Given this list of marker genes ST8SIA1, AKAP13, CLDN12, GPCPD1, TIGD2, FRMD6, STAT2, BCL2A1, JCAD, TRIM25, ASAP1, SFXN3, SCD, FRMD4B, GALNT7, DENND11, CALCOCO1, PIK3CG, KDM1A, TTC3, MLLT3, IRGM, BCKDHA, EPSTI1, RPS6KA3, PBK (PDZ binding kinase), ZNF496, SYTL2, SMS (NCBI Gene Id 6735), NFE2L2, ZNF703, ENTPD1 (NCBI Gene Id 953), HIVEP3, CD82, UNG, MGAT4A, AAK1, CAPN3, TMEM243, AKT3, RALGPS2 (Ral GEF with PH domain and SH3 binding motif 2), CNOT6, PPP1R16B, NSG2, PRNP, NRN1, C19orf12, EXTL2, CIR1, IKZF3, ITK, TIAM1, DUSP2, RAD52, FOSL2, PRXL2A, MTNAP1, SESTD1, BATF3, SLC30A1, ICAM1, TENT5C, PCK2, TNFSF4, IRF9, JMJD1C, CYP2S1, BMP2K, FOXP1, VARS1, SPECC1, TOR3A, USP32, EPAS1, FAM107B, ANXA3, NFIL3, RGS10, LIF, MAEA (macrophage erythroblast attacher, E3 ubiquitin ligase), NIBAN1, NATD1, TES, YPEL2, ZNF367, RSPH3, CHD7 (NCBI Gene Id 780907), TMEM40, CUL7, SERPINF1, PDE3B, C3orf80, MED30, ABHD17B, OSER1, CCNG2, ERI2, PRR5L, SAMSN1, WDR12, GAB2, DUSP4, DDX50, MXI1, MCM3, CD9, NGLY1, AHR, ZBTB11-AS1 (ZBTB11 antisense RNA 1), FAM117B, C1QTNF12, NSD3, RMND5A, PLEK, TNFAIP8, MELK, PLCG1, ZNF250, RFX5, OGA, RRAGD, IDH2, TLE1, RCSD1, ST13, PARP14, SFMBT2, DEGS1, MTURN, PTGER4, VEZF1, GJA1, RELB, WDR6 (WD repeat domain 6), MAPKAPK2, RESF1, PSPC1, DAPL1, TNFSF13B, VCL, MTMR3, APEX1 (apurinic/apyrimidinic endodeoxyribonuclease 1), MAPK6, INPP5F, SLC25A53, ARHGAP15, PPP2CB, CASP7 (caspase 7), HMGB3, DAP, DGKD, TUT4, HECA, ABTB1, GOLIM4, KLRD1, SSH2 (NCBI Gene Id 85464), ATXN1, GBP6, NAMPT, RASGRP1, IL17RA, MGAT5, TBX21, PPP1R10, UBE2E3, ARL5A, PIP4K2A, TBL1XR1, CCDC122, LITAF, TENT2, TLCD2, SLC15A3, TAF5, DOCK10, NDRG1, RNF149, TGFB1, ADAMTS6 (NCBI Gene Id 345667), HDAC5, UNC93B1, AGL, CD96, MICAL1, SRPK1, CPD, SLC41A1, ACBD6, NOPCHAP1, CDT1, MXD1, FDPS, BIVM, FADS2, ALDOC, MXD4, ARAP2, TAP1, KTN1, here is a description of the gene set: Human Gene Set: GSE22601_IMMATURE_CD4_SINGLE_POSITIVE_VS_DOUBLE_POSITIVE_THYMOCYTE_DN Genes down-regulated in immature CD4 single positive cells versus double positive thymocytes. species: Homo sapiens T cells develop from progenitors that migrate from the bone marrow into the thymus. Thymocytes are subdivided roughly as being double negative (DN), double positive (DP), or single positive (SP), based on the expression of the CD4 and CD8 coreceptors. The DN stage is heterogeneous and can be subdivided into four distinct subsets in mice based on the expression of CD44 and CD25. In human, three distinct DN stages can be recognized: a CD34+CD38−CD1a− stage that represents the most immature thymic subset and the consecutive CD34+CD38+CD1a− and CD34+CD38+CD1a+ stages. Human DN thymocytes mature via an immature single positive (ISP CD4+) and a DP stage into CD4+ or CD8+ SP T cells that express functional T cell receptors (TCR) and that exit the thymus. In this study, gene expression was measured in each of these nine stages. from publication Dik WA, Pike-Overzet K, Weerkamp F, de Ridder D, de Haas EF, Baert MR, van der Spek P, Koster EE, Reinders MJ, van Dongen JJ, Langerak AW, Staal FJ (PMID 15928199)